Given this list of marker genes GLRX2, SVIL, MAP7D1, SEMA4A, ITGAL, STXBP2, TNFRSF1B, ANXA2, PICALM, SLC7A7, HPCAL1, MYO1F, MNDA, THEMIS2, S100A8, PISD, BCL3, DUSP3, TNFSF13, FEZ2, ILK, TNFAIP2, LILRB1, FTL, UQCRC1, NCF2, CHST15, SLC27A3, GNS, IL6R, GRN, RTN4, SEMA4D, CTSD, SDCBP, SLC16A6, RXRA, CD14, ATP5MJ, CKLF, EVI2A, VAMP3, PTPRE, TMEM50A (NCBI Gene Id 23585), SLC16A3, RIN2 (Ras and Rab interactor 2), TNFRSF10B, LGALS3, C5AR1, IRAK3, ZMIZ1, RAB31, RNH1, BID, TKT, TIMP2, SLC31A2, ATP1A1, PLBD1, CLEC7A, TMEM11, IFNGR1, NDUFS6 (NADH:ubiquinone oxidoreductase subunit S6), KLF13, IMMT, SRGN, SERPINA1, PGD, GET3, TLR2, SLC11A1, PSAP, CDC42EP3, CTSB, DYNLT1, MOGS, EIF4G1, RAB5IF, LILRB2, METTL9, PTTG1IP (PTTG1 interacting protein), HCK, PLXND1, TALDO1, TPP1, CSTA, MTMR14, CD93, NUP62, G6PD, AKR1A1, S100A10, VCAN, PPT1, EXT1, ADAP1, ATP6V1A, UBR4, PRKCD, CLTA, RHOG, TNFRSF1A, TYROBP, NOTCH2, SERPINB6, ID2, LILRB3, HSPA1A, PLXNB2, TPI1, LILRA2, GPX1, LYZ, TIMM8B, TWF2, ACOT9, ITGAM, TRNAU1AP, CEBPB, RTN3, NOD2, LGALS1, S100A11, CD300A, FTH1P5, S100A12, MACROH2A1, WARS1, TOP1, KCTD12, GCA, ABR, PXN, FCGR2A, GYG1, ANXA1, CLTC, RAB14, HIPK1, ATP6V0C, MAPKAPK3, EFHD2, PKM, VIM, SULT1A1, SEL1L, S100A9, LY96, VASP, KLF10, HADHB, HEXB, CKAP4, CCT6A, MGAT1, GAPDH, RNF130, FCER1G, PPFIA1, MYDGF, ARRB2, NPL, DPYD (dihydropyrimidine dehydrogenase), CTBP2, NEU1, TMED1, TCF7L2, NDUFS1, SGK1, IL10RA (NCBI Gene Id 3587), LRPAP1, ATG3, CSNK1A1, CAPG, TBC1D2, PAK1IP1, ASAH1, SNAP29, ANXA2P2, IGF2R, NAGK, IFI30, QPCT, IQGAP2, GLRX, ALDOA, ATXN1, CHMP2A (charged multivesicular body protein 2A), CASP1, CSF2RB, DUSP6, PNPLA6, CERS6, MAFB, CREG1, RBM47, RPS6KA1, S100A4, TRIM8, MICAL2 (microtubule associated monooxygenase, calponin and LIM domain containing 2), here is a description of the gene set: Genes down-regulated in comparison of naive B cells versus day 0 monocytes. from publication Abbas AR, Baldwin D, Ma Y, Ouyang W, Gurney A, Martin F, Fong S, van Lookeren Campagne M, Godowski P, Williams PM, Chan AC, Clark HF (PMID 15789058) species: Homo sapiens Human Gene Set: GSE22886_NAIVE_BCELL_VS_MONOCYTE_DN Immune cell-specific expression is one indication of the importance of a gene's role in the immune response. In order to identify such patterns, we set out to broadly profile gene expression in a variety of immune cells.